The following is a description of a gene set: species: Homo sapiens The region of a cell that lies just beneath the plasma membrane and often, but not always, contains a network of actin filaments and associated proteins. Human Gene Set: GOCC_CELL_CORTEX, and this is the list of marker genes: MARCKS, PTK2, RHOA, KRT19, MAPRE1, FABP2, ARC, FGFR2 (NCBI Gene Id 2263), GSN, MYZAP, ARHGEF7, ARFIP2, CTBP1 (C-terminal binding protein 1), SPINK5, CLIP4, MYL12B, FERMT2, SPIRE2, EXOC6, TPM4, PPP1R9A, PLA2G4C, CRIP2, FNBP1L, PKD2, TRAF6, DCTN1, DLG4, TMC2, GRM7, MYO6, LASP1, MPP7, PRKCZ, BFSP1, ERMN, TRPV4, CTTNBP2, STIMATE, MKLN1, PPFIA1, ANLN, CTSZ, FMNL1, BSN, SEPTIN8, SEPTIN12, MYO1A, RDX, MYRIP, CALD1, FIGNL2, CTNNA2, EMD, FLOT2, MYO7A, FRMPD1, SELE, ACTN1, HMCN1, PDE4DIP, EXOC4, EPS8, PARD6G (NCBI Gene Id 84552), AXIN1, KNCN, MYO5B, FAM110C, EXOC2, CTTN, SHROOM3, TBCB, LAMC2 (laminin subunit gamma 2), SEPTIN6, FSCN1, STK39, SHROOM4, FLNB (filamin B), MAEA, SPTAN1, RIMS3, NEDD9, GAD1, MTSS2, MYL9, FRY, SNCA, SEPTIN9, SEPTIN11, IQGAP2, HMCN2, WDR1, PLS1, PRKD1, AKT2, ITPR2, PTK2B, NRBP1, ERC1, SLC4A1, KIF21A, NLRP5, EXOC3, CAPZA3, SPIRE1, TCHP, PCLO, CAPZA2, GRK4, OR2C1, CAV1, PARD3, DBNL, EEF1A1, C2CD2L, TSC1, SPTBN5, SPTBN2, SNX9, CYTIP, ACTR1A, PIEZO1, GPSM2, PJVK, GUCY1B1, HIP1, LLGL2, GPSM1, AKAP12, ARV1, EPB41L2, ENO1, KCNC3, WASHC1, CAPZB, MYO1C, ARF6, NDFIP1, NCL, SEPTIN2, SPRR4, SEPTIN1, TRIP10, NF2, DLC1, RIMS2 (NCBI Gene Id 9699), STXBP1 (syntaxin binding protein 1), SEPTIN14, CD302, DENND2B, STOX1, MYO1D (myosin ID), PHLDB2, EXOC3L2, SEPTIN7, SEPTIN4, ACTN2, PARD6A, STIM1, MYADM, CAPZA1, OSBPL8, SLC2A1, HAX1, CDH2, KHDC3L, RAI14, SAPCD2, MPP1 (NCBI Gene Id 4354), GIPC1 (GIPC PDZ domain containing family member 1), GMFG, NSMF, WASL, FAM110A, PARD6B, SCIN, FRYL, PSEN1, DCTN4, EPB42, EXOC5, EZR, FCHSD1, EXOC3L4, CORO1C, NUMA1, SEPTIN5, TNFAIP2 (TNF alpha induced protein 2), GMFB, MED28, RTKN, CLIP3, NEDD4, RIMS1, ARHGAP33, EXOC1, EXOC8, FER, ACTR2, GYS2, KDF1, PARD3B, ECT2, ASTN2, C2CD5, RIC8B, ACTN3, MYH9, CLIP1, MICAL3, RAB10, CAPN2, GYPC, DSTN, RIC8A, MISP, PHLDB1, PPP1R9B, ASPH, DBN1, PDZD4, TMEM201, BIN2, DMTN, BFSP2, TRAK1, ILK, TMOD1, CORO1A, FLNA, EXOC7, ITCH, SHROOM2, SLC38A8, COBL, PPFIA3, CALB1, CFL1, CIB2, PAFAH1B1, SNAP25, CLDN5, NOS2, HIP1R, PFN1, SPTBN1, MELK, OSBPL2, OOEP, ACTN4, PLEKHH2, KANK1, MYH10, CLASP1, WDPCP, CSNK1G2, MLPH, FGF1, PRKCB, COTL1, ADD3, CTNNB1, CLIP2, ARHGAP32, ACTB, IQGAP1, EPB41, CDH1, FLOT1, FMN2 (formin 2), RASAL3, TRPC4, PXN, OSR1, KIAA1614, PFN4, AKT1, IQGAP3, RYR1, AKAP13, MYO10, SPTB, MYO9B, EXOC6B, FNBP1, CLIC5, GNAI1, FGB, SPTA1, DST, PIEZO2, PPFIBP1, SEPTIN3, CEP85, CALB2, AGTRAP, DYNC1H1, ERC2, LLGL1, SH3BP1, STIL, TLE6, CABP1, CLASP2, VCL, POTEF, RAC1, SEPTIN10, CNKSR1, EXOC3L1, SPTBN4, RAPGEF3, LANCL2, GRB2, ENO2, SHROOM1, TRAF2, GLRX3, MAP2K1, INSC, CAP1